The following is a description of a gene set: A inflammatory cell death process associated with the generation of pyrogenic mediators that result from the activation of gasdermins. species: Homo sapiens Human Gene Set: GOBP_PYROPTOTIC_CELL_DEATH, and this is the list of marker genes: GSDME, NINJ1, GSDMD, GZMA, GSDMB